Given this list of marker genes AGER, MCAM, RPSA2, BCAM, RPSA, here is a description of the gene set: Human Gene Set: GOMF_LAMININ_RECEPTOR_ACTIVITY Combining with a laminin, a glycoprotein that constitutes the majority of proteins in the basement membrane, to initiate a change in cell activity. studied in species Homo sapiens